Given this list of marker genes APOE, COL7A1, UBAC2 (UBA domain containing 2), HGD, GPR35, TTR, LYZ, RET, TET2, IL10, GSN, CCR1, IL31RA, NLRP3, HLA-B, KLRC4, PRNP, KIT, APOA1, POLA1, FAS, TCF4, TNFRSF1A (NCBI Gene Id 8077), IFNGR1, FGA, MEFV, ERAP1, ITM2B, ASXL1, SAA1, IL12A, STAT4, MMP1, SEMA4D, TLR4, PSEN2, OSMR, MST1, C4A, B2M, CST3, TACSTD2, NLRP1, IL23R, SRSF2, IL12A-AS1, SLC7A7, CCND1, LIG4, APP, here is a description of the gene set: studied in species Homo sapiens Amyloidosis The presence of amyloid deposition in one or more tissues. Amyloidosis may be defined as the extracellular deposition of amyloid in one or more sites of the body. Human Gene Set: HP_AMYLOIDOSIS